The following is a description of a gene set: Human Gene Set: GOBP_TYPE_B_PANCREATIC_CELL_DIFFERENTIATION The process in which relatively unspecialized cells acquire specialized structural and/or functional features of a type B pancreatic cell. A type B pancreatic cell is a cell located towards center of the islets of Langerhans that secretes insulin. species: Homo sapiens, and this is the list of marker genes: NKX2-2 (NK2 homeobox 2), NKX6-1, IER3IP1, PAX6, INSM1 (NCBI Gene Id 8196), ONECUT1, SIDT2, RHEB, DLL1, BMP5, GSK3A, BMP4, BMP6, PDX1, CLOCK, BAD, BMAL1, MIR541, PDPK1, WNT5A, CDK6, PAX4, GDF11, SMO, BHLHA15, RFX6, RFX3, GSK3B, CDH2 (NCBI Gene Id 1000), AKT1, GATA6